The following is a description of a gene set: Human Gene Set: GGCCAGT_MIR193A_MIR193B studied in species Homo sapiens Genes having at least one occurence of the motif GGCCAGT in their 3' untranslated region. The motif represents putative target (that is, seed match) of human mature miRNAs hsa-miR-193a and hsa-miR-193b (v7.1 miRBase)., and this is the list of marker genes: NAV3, SPATA7, SRSF2, MYCN, GLS2, ARPC5, CAMTA1, LAMP2, ERBB4, IRF2BPL, FLRT3, NUFIP2, TMEM30A, ZNRF1, CCDC28A, LRRC8A, CD47, JADE2, AP2M1, SIX4, IGFBP5, RSF1, MMP19, MKLN1, CALB1, EN2, CAMK2N2, SIAH1, SCYL3, HOXD13, LUZP1 (leucine zipper protein 1), CBX7, DYRK1A, SLCO2A1 (NCBI Gene Id 6578), SLC39A5, MCL1, DNAJC13, CTDSPL2, BRPF1, MED14, NPAS4, ING5, FHDC1, UBAP2, HSPA14, PTPRF, YWHAZ, KCNJ2, NRIP1, DCAF7, STMN1, PLAU, ZHX3, PTEN, BAZ2A, ZBTB5, ANKFY1, SON, CELSR2, E2F6, PPP2R5C, NOVA1, LAMC2, ACACA, RAB6B, ETV1, TBL1XR1, ETV6, ZC3H11A, RUNX1T1, GRB7, ZIC3, KCNH8, PAK4, CDK10, MMP16, ARHGEF12, CNBP, CNOT6, STX16, MAP3K3, KMT2A, MAX, MARF1, KIT, CAPN3, DIO2, TAOK2